Given this list of marker genes Ntrk3, Snap91, Snca, Nlgn1, App, Farp1, Dkk1, Lrrtm1, Cacna2d3, Slitrk3, Slitrk2, Il1rapl1, Vps35, Grid2, Ntng2, Lrrc4b, Igsf11, Lrfn3, Nrg1, Efnb3, Il1rapl2, Eif4g1, Picalm, Lrfn5, Fzd1, Slitrk1, Nlgn3, Clstn3, Arf6, Wnt7a, Mdga1, Wnt3a, Lrfn4, Lrrtm3 (leucine rich repeat transmembrane neuronal 3), Nrxn1 (NCBI Gene Id 68042), Nlgn2, Il1rap, Gpc4, Cbln1, Mdga2, here is a description of the gene set: Mouse Gene Set: GOBP_REGULATION_OF_PRESYNAPSE_ORGANIZATION Any process that modulates the physical form of a presynapse. species: Mus musculus